The following is a description of a gene set: from publication Chebotaev D, Yemelyanov A, Zhu L, Lavker RM, Budunova I (PMID 17146443) Human Gene Set: CHEBOTAEV_GR_TARGETS_DN Genes down-regulated in follicular epithelial stem cells after transgenic expression of GR under control of the keratin5 (K5) promoter. Glucocorticoids are potent inhibitors of mouse skin tumorigenesis. The glucocorticoid control of cellular functions is mediated via the glucocorticoid receptor (GR), a well-known transcription factor. Recently, we generated transgenic mice overexpressing GR under control of the keratin5 (K5) promoter, and showed that K5.GR animals are resistant to skin carcinogenesis. Follicular epithelial stem cells (SCs), located in the bulge region of the hair follicle, are believed to be one of the target cells for skin carcinogenesis. We found that the number of putative hair follicle SC detected as label-retaining cells was significantly less in the K5.GR transgenics compared to wild type (w.t.) littermates. We also showed that GR overexpression led to a reduction in the clonogenicity of the follicular epithelial SCs. We evaluated the global effect of GR on gene expression in a population of follicular SC-enriched bulge keratinocytes isolated by fluorescence activated cell sorting. We found that GR affected the expression of numerous bulge SC 'signature' genes, genes involved in the maintenance of SC and progenitor cells of non-epidermal origin and proapoptotic genes. Our findings underscore the important role of GR signaling in the homeostasis of follicular epithelial SCs, and suggest that the reduction in their number may underlie the tumor suppressor effect of GR in the skin. species: Mus musculus, and this is the list of marker genes: THBS2, FGGY, CACNB4, FKBP14, PALLD, IGDCC4, USP18, GPHA2, CLEC11A, PRKD1, GBP4, NRCAM (neuronal cell adhesion molecule), TSLP, PLAT, TUBA8, TRDC, CXCL12, CA8, AR, TMEM255A, CNN2, GFRA2, SVIP, STAG3, PHLDB2, LRRN3, SAMD12, HSD17B13, ATP6V1C2, ZNF704, GPAT3, LRP4, CFB, C2, ANKRD6, KLHL10, SH3KBP1, RSAD1, IL2RG, PFN2, RHOBTB3, C11orf65, IGFBP3, IRF4, TLCD4, TNFRSF11B, PTPN14, NEXN, PPP1R3C, MYEF2, LIMCH1, SLC14A1, KCTD4, TCEA3, GUCA2A, NRXN3, RTN2, TGFB2, COL1A2, SYNE1, FLRT2, SMIM22, RASA3, MME, PCDHB5, CHSY3, TAFA5, DAB1, PDLIM3, PLA2G4A, GPRASP2, LOXL1, S100A4, FKBP10 (NCBI Gene Id 60681), PPP2R3A, SORCS3, RSPO3, DMPK, CPE, SLC39A10, GNA14, GDNF, VWA1, GPM6B, SLC38A4, TSC22D1, PKIA, STBD1, PLCXD2, ARSI, SYT9, CRISPLD2, ZFP36L1, IGFBP5, AMY2B, VAV3, SMARCA1, MINAR2, CALHM5, NPTX1, MOB3B, ZSCAN18, SOX21, CHIC1 (NCBI Gene Id 53344), ATP8A1, MYL9, SIPA1L3, FCGBP, DNAJC6, JAZF1, SARDH, EFEMP2, CNTN1, GSTA1, PTGER4, DPY19L1, BCL2L15, S100A3, MEI4, HTR1B, COTL1, PDZRN4, ELAVL2, CH25H, CPEB1